Given this list of marker genes HARS2, ALG8, PSMD8, NEDD8 (NCBI Gene Id 82917), KPNA2, UNG, TMED2, BAG5, RAB5A, RPA1, PSMC1, RAB1A, PSMB6, HNRNPAB, PSMB4, PSMC6, C6orf62, COX4I1, PSMD7, PPP2R1A, SDHA, SEM1, SEC13, DPM1, UBAP2L, ELOC, PSMC4, GSPT1, EIF5, COPS5 (NCBI Gene Id 10987), PPP1CA (NCBI Gene Id 5499), HAT1, RUSC1, CNIH1, MAML1, USP10 (NCBI Gene Id 9100), KARS1, FBXW11, SLC25A1, TMEM106C (NCBI Gene Id 79022), RNF6, FAM20B, PSMA3, XPC, DDX1, PSMD9, HSPA9, PRKAR1A, EIF2B2, SUMO1, LSS, SF3B2, SP3, KHDRBS1, ADAR, CFDP1, SOD1 (superoxide dismutase 1), CNBP, PSMA2, SARS1, PDAP1 (PDGFA associated protein 1), ARCN1, CRK, BUD31, EIF2B4, SMG7, RER1, DCTN2, NDUFS1, CANX, BANF1, COX5A, PSMB5, RAD21, EIF4E2, LYPLA1, SDHC, RPL36AL, KIF2A, POP5, GATD3, GMFB, CLN3, SPTLC1 (serine palmitoyltransferase long chain base subunit 1), RPP38, G3BP1, HSBP1, RFK, PPP1R7, AP2S1, SNRPG, MAPK6, ETFA, ENSA, COG4, YWHAB, ATOX1, GGCT, YWHAE (NCBI Gene Id 7531), DNPEP (aspartyl aminopeptidase), ARF3, PDCD6, PPP6C, NDUFAB1, RAC1, SRP19, SYPL1, DYNC1I2, ATP6V1H, TRAPPC3, FAM120A, UBR5, TBCA, PEX11B, CYC1, UBA1, ATP5MF, MDH1, HSPA4, VPS72, COA1, PTPA, ELOB, RAD23B, SPCS2, BCAP31, PRMT1, UBE4A, COPB2, SSBP1, PSMC3, PSMC2, COIL, SKP1, DAP, ATP2A2, SEPHS2, URM1, HNRNPA3P1, MTDH, SHMT1, STOML2, UTP18, TPGS2, PGRMC1, VTI1B, DLD, PRPSAP1 (NCBI Gene Id 5635), SET, TMEM97, MBD4, SART3, PPP2R2A, NSDHL, EBAG9, ATP5PF, MYL11, CSNK2B, PARG, POLR2I, RAB9A, URI1, ZZZ3, TMBIM6, MAD2L1BP, RARS1, TMEM147, PSMB2, SRP9, MORF4L2, LSM3, MTA1 (metastasis associated 1), BZW1, SEC61G, PRDX3, VCP, CYCS, here is a description of the gene set: Human Gene Set: MORF_RAD23B species: Homo sapiens Neighborhood of RAD23B Neighborhood of RAD23B RAD23 homolog B (S. cerevisiae) in the MORF expression compendium